Given this list of marker genes IFT43, PPFIA2, HAUS6, CLK4, KIAA0825, FOXC1, XPNPEP3, COL17A1, RNF138, DTNA, ADGRE3, ABI1, AHR, KLHL5 (kelch like family member 5), TMEM65, CIAO2A (NCBI Gene Id 84191), PM20D1, BASP1, ZNF875, BRINP3, DCLK1, SAMD12, SHE, THSD7A, HSF5, NADSYN1, LAPTM5 (NCBI Gene Id 7805), SAYSD1, MAPK10, UTP25, LRP2BP, THBS2, ICOS, TGFA, A4GNT, ZSCAN1, PRXL2C, COL8A1, OSGEPL1, CCAR1, HYCC2, GKAP1, AMER2, P4HA1, UBE2J1, FUT9, COA7, NLN, CEP57, RIC1, HNRNPC, DAB2, KLHL14, PCCA, RFXAP, TENT2, WDR89, CD83, ENDOD1, PTGDR (NCBI Gene Id 5729), SHOC2, MBNL1, DCUN1D3, CLDND1, SRGAP2C, PGM2L1, NR3C1, TSHZ2, GAN, SERP1, GTF2A1, C2CD4A, CRLF3, here is a description of the gene set: Genes predicted to be targets of miRBase v22 microRNA hsa-miR-4439 in miRDB v6.0 with MirTarget v4 prediction scores > 80 (high confidence targets). Human Gene Set: MIR4439 studied in species Homo sapiens from publication Chen Y, Wang X (PMID 31504780)